The following is a description of a gene set: species: Homo sapiens from publication Belyaev NN, Biró J, Athanasakis D, Fernandez-Reyes D, Potocnik AJ (PMID 22581009) Human Gene Set: GSE24142_ADULT_VS_FETAL_EARLY_THYMIC_PROGENITOR_UP Genes up-regulated in comparison of adult thymic progenitors versus fetal thymic progenitors. Development of T-cells provides a unique opportunity to study cell-fate determination due to the accessability and the well defined stages of developmental stages. In order to understand the genetic programs underlying fetal and adult T‑cell fate specification we subjected highly purified fetal and adult T-cell progenitor populations to a genome‑wide transcriptional analysis. The aim was to identify molecular elements that govern T-cell fate specification as a whole but ultimately to isolate elements that were specific for a given population in a specific developmental window., and this is the list of marker genes: NR1D2, PARP8, ITSN1, CBFA2T3, USP18, CDK20 (NCBI Gene Id 23552), RIPOR2, MEOX1, IL18, HDAC11, KIF1C, REPIN1, HLA-DMA, ZBTB8A, IGFBP4, MAP3K8, C9orf72, RASSF8, RNF6, FGF13, FBLIM1, WFS1, CA2, B3GNT5, OSBPL1A, KDM7A, LRRK2, CD86 (CD86 molecule), TMEM176B, PLBD1, APCDD1, EPS8L1, CD72, SYNJ2, PIP4K2A, LYZL1, RRAS, KCTD2, ACP2, RMND5A, DNER, ZDHHC14, GAB1, ASB4, CCDC120, GABBR1, PITPNC1, IRF8, SH3GL2, GRIP1, ASAH2, DEPTOR, MAU2, RYBP (NCBI Gene Id 23429), ERBB3, EPN3, RELL1, ECE1, TNFRSF18, SLCO3A1, VIM, DNAJB9, LYST, HLA-DOB, SLC44A1, GIMAP6, DBNDD2, BMP5, IL27RA, MYLIP, PKD2, RAB2B, CCDC9, P2RY6, FAM13B, CHGA, ABHD4, BBX, MDFIC, TRAF3IP2, CCM2, NR3C1, TP53INP1, LGALSL, JARID2, TOR1B, HOXA9, KMO, RASA2, MAST3, LZTS2, EEIG1, ANXA4, AOC1, HLA-DRB1, IFT81, MCL1, CTSS, SYNE1, APBB2, CDKN2B, PEX11A, SELL, MTSS1, LPP, ZNF623, RBM18, SCNN1A, P3H4, PIK3CA, ULK2, EIF4E3, PTGER2, ZNF574, DDX60, ABCA1, SSTR2, N4BP3, PTGIR, SATB1, PISD, MKRN1, SLC15A2, CPQ, CTNNA1, AR, IRS2, BIRC3, SLC50A1, RPS6KA2, GON4L, ATG12, FHIP1B, SSTR3, GPR3, GPX2, TRIM34, ZFP82, SEC62, P2RY14, IGKC, SPRY2, GPRC5B, ELK4, SPICE1, IL18R1, ACVR2A, CYP4V2, SYTL4, VWA7, SLC30A4, TRAPPC2, PRKCZ, KMT2E, KCNH3, ZNF260, ADCY6, CIPC, LTO1, CYTH1, TLR7 (toll like receptor 7), PRKCE, BCL6, RNF166, PAFAH2, MMP15, DNAJC4, KLF9, CTSG, IFI44, CASP1, SPARCL1, STK17B, ARMC12, CAMTA2, WDFY2, HSD17B8, HLA-B, FGB, ZNF329, NDRG1, KRT14, BRWD1, MXD4, FLT3, LTBP3, SESN3, ST6GAL1, ST3GAL2, KCTD4, TANC1, GSTM5, PATJ, MYL6B, ZBTB20, UNC119B, CLEC4E, DUSP22, SFXN3, LMO2